Given this list of marker genes Micu1, Hamp2, Commd1, Vamp8, Cav1, Fkbp1b, Nedd4, Wnk1, Nedd4l, Slc30a1, Stx7, Pacsin3, Pcsk9, Camk2d, Rack1 (NCBI Gene Id 14694), Tnni3, Lamp1, Bcl2, Stx1a, Wnk3, Slc15a1, Stx8, Ano9, Stom, Scn1b, Ywhae, Scn3b, Calm2 (NCBI Gene Id 75700), Lamp2, Cav3, Ensa, Itpr1, Wnk4, Phpt1, Lynx1, Wnk2, Kcne4, Calm1, Mcub, Calm3, Kcnk2, Vti1b, Stoml1, Hamp, Cftr, Tmc7, here is a description of the gene set: studied in species Mus musculus Mouse Gene Set: GOMF_TRANSPORTER_INHIBITOR_ACTIVITY Binds to and stops, prevents, or reduces the activity of a transporter.